The following is a description of a gene set: from publication Zirn B, Samans B, Spangenberg C, Graf N, Eilers M, Gessler M (PMID 15897880) studied in species Homo sapiens Human Gene Set: ZIRN_TRETINOIN_RESPONSE_UP Wilms tumor is one of the most frequent neoplasias in children. Our previous microarray screening in a large series of Wilms tumors revealed several candidate genes that are deregulated in advanced tumors and are part of the retinoic acid signaling pathway. To investigate whether retinoic acid could be employed as a novel therapeutic agent in these tumors, we treated cultured Wilms tumor cells with different concentrations of all-trans retinoic acid (ATRA) and assessed gene expression changes by real-time RT-PCR as well as microarray analysis. Several genes like RARRES1, RARRES3, CTGF, CKS2, CCNA2, IGFBP3, UBE2C, CCL2 or ITM2B that were previously found to be deregulated in advanced tumors exhibited opposite expression changes after ATRA treatment. In addition to enhanced retinoid signaling, the transforming growth factor-beta (TGFbeta) pathway was strongly activated by ATRA treatment of Wilms tumor cells. Both the retinoic acid and the TGFbeta pathway mediate inhibition of cell growth. These findings represent the first molecular evidence of a potential benefit from ATRA treatment in Wilms tumors. Genes up-regulated in MS427 cells (Wilms tumor with normal WT1) after treatment with 10 microM tretinoin (ATRA) for 24 h., and this is the list of marker genes: AKAP12, IQCK, PLAUR, SLC38A2, DHRS3, PLGLB1, SLCO2A1, VGLL3, TAL1, TINCR, THSD4, PLAAT4, RARG, RARB, PLK2, VMP1 (NCBI Gene Id 81671), NID2 (nidogen 2), CCL2, CCN2, LAMA4